The following is a description of a gene set: Stimulation of osteoblast differentiation from mesenchymal stem cells is a potential strategy for bone repair. Bone morphogenetic proteins (BMPs) that induce osteoblastic differentiation have been successfully used in humans to treat fractures. Here we outline a new approach to the stimulation of osteoblast differentiation using small molecules that stimulate BMP activity. We have identified the amiloride derivative phenamil as a stimulator of osteoblast differentiation and mineralization. Remarkably, phenamil acts cooperatively with BMPs to induce the expression of BMP target genes, osteogenic markers, and matrix mineralization in both mesenchymal stem cell lines and calvarial organ cultures. Transcriptional profiling of cells treated with phenamil led to the identification of tribbles homolog 3 (Trb3) as a mediator of its effects. Trb3 is induced by phenamil selectively in cells with osteoblastic potential. Both Trb3 and phenamil stabilize the expression of SMAD, the critical transcription factor in BMP signaling, by promoting the degradation of SMAD ubiquitin regulatory factor 1. Small interfering RNA-mediated knockdown of Trb3 blunts the effects of phenamil on BMP signaling and osteogenesis. Thus, phenamil induces osteogenic differentiation, at least in part, through Trb3-dependent promotion of BMP action. The synergistic use of small molecules such as phenamil along with BMPs may provide new strategies for the promotion of bone healing. Genes up-regulated in M2-10B4 cells (osteoblast) in response to phenylamil. species: Mus musculus Human Gene Set: PARK_OSTEOBLAST_DIFFERENTIATION_BY_PHENYLAMIL_UP from publication Park KW, Waki H, Kim WK, Davies BS, Young SG, Parhami F, Tontonoz P (PMID 19433444), and this is the list of marker genes: RGCC, DLK2, CHAC1, COX6A2, RGS3, CYP26B1, TRIB3, CLDN1, THBS1, SLC6A9, FST, ALDH1L2